Given this list of marker genes ZNF394, RABGAP1, BCCIP, LACTB, MRPS34, RPE, ZKSCAN3, SLC6A12, KLRD1, HELB, NEK9, RPP21, TRIM8, CD72, PRKCSH, HSPA9, PFKL, PCNX1, CD37, GRAMD1A, FTL, IL12RB1, TMBIM1, AHCYL1, TCF12, NLRX1, ZNF22, NPRL2, BCAS2, TRAPPC1, MCM3AP, RETREG2, MMD, ARHGAP10, SLC5A8, ZNF622, PSMA1, ANPEP, SMC5, DGAT1, COG8, BET1L, BRD4, MINDY1, TEX14, ARAF, LYRM2, IL17RA, ZNF503, GARS1, B3GALT4, MKRN2, TRPS1, FKBP15 (FKBP prolyl isomerase family member 15), ELK3, CAMTA2, SAMD8, CMKLR1, MBP, ARMCX5, GABARAPL2, TM9SF4 (NCBI Gene Id 9777), OAZ2, ACSL1, GPR146 (G protein-coupled receptor 146), PPCDC, SORL1, NFKBIL1, PIGH, APP, CDT1 (chromatin licensing and DNA replication factor 1), KCTD12, FBXO31 (F-box protein 31), SLC22A13, NCF1, DCTN2, MLLT10, CERK (ceramide kinase), VTI1B, MR1, ARHGAP45, CARS1, SUGP1, ZNF24 (NCBI Gene Id 7744), CD47, CCNT2, EGLN2, SON, GPRIN1, MAD2L1BP, IFITM3, DYNLRB1, MIDN, WBP1, RCC1L, SRSF11, CDK5RAP2, SPOP, CFAP20, ATP6V1A, PRPF39, MRPS7, SH3BGRL2, HLA-G, CIAO2B, TMCO6, SPG11, GTF3C4 (general transcription factor IIIC subunit 4), VIRMA, TRMT2A, SH3BP4, METTL5, CSNK1G2, C6orf136, TYW1, BUD31, TMA16, FXYD2, DHX57, GFUS, PACS2, IFNGR2, ZMYND8, SUGT1, ATXN2, AZIN1, ZBP1, DBNL, ANAPC7, CNOT3, IFNAR2, TBC1D20, AICDA, KANSL2, RBKS, CHMP1A, SIRPA, SMPDL3A, SENP3, TTYH2 (tweety family member 2), MIA2, CDC37L1, GBA1, ACADVL, PRDX5, GCLC, METTL9, PFKFB3, ATOSB, KLHL36, TESK1, RAP2B (RAP2B, member of RAS oncogene family), MTURN, TRIT1, CTU1, PTGES, FBXO33, SUMF1, AMPD3, TNFRSF1B (NCBI Gene Id 7133), KIF3A, CISD1, JPH2, WBP2, RIPK1, NDUFA6, LFNG, COA5, PACC1, RNF130, GPR65, SLC4A1AP, SSNA1, TPRG1L, LPO, SLIRP, SFSWAP, LRRC42, LY96, TSC22D4, PLAAT3, PRRG2, TRIM32, TRPC6, CSF2, BCDIN3D, HFE, ZNHIT2 (NCBI Gene Id 741), TULP3, KLHDC3, TUBGCP5, NAA60, TMEM11, GOSR2, ECI1, SLC6A20, COMTD1, STMP1, FBXO25, COA7, here is a description of the gene set: mouse primary BMDCs were stimulated with tlr ligands and gene expression changes were profiled on Affymetrix arrays Human Gene Set: GSE17721_4H_VS_24H_POLYIC_BMDC_DN Genes down-regulated in comparison of dendritic cells (DC) stimulated with poly(I:C) (TLR3 agonist) at 4 h versus those stimulated at 24 h. from publication Amit I, Garber M, Chevrier N, Leite AP, Donner Y, Eisenhaure T, Guttman M, Grenier JK, Li W, Zuk O, Schubert LA, Birditt B, Shay T, Goren A, Zhang X, Smith Z, Deering R, McDonald RC, Cabili M, Bernstein BE, Rinn JL, Meissner A, Root DE, Hacohen N, Regev A (PMID 19729616) species: Homo sapiens